Given this list of marker genes UBA2, DBI, CKAP2, RHPN2, AURKA, YWHAQ, BLTP3B, KPNA4, MCM5, PYCR1, CDK1, PANK1, SUCLG1, PKIB, OSGIN2, CTPS1, CDC45, SOAT1, CCNB2 (NCBI Gene Id 9133), TM4SF1, MAD2L1, MSH2, ASS1, BIRC5, TXNRD1, DEK, IL2RA, ARHGEF26, GMNN, DYNLT3, SLC11A2, RAF1, NEDD9, H3C10, EZH2, EID2, NETO2, CSTF3, NAA50 (NCBI Gene Id 80218), NXT2, GPA33, LINC00173, TSC22D2, CDK2 (NCBI Gene Id 1017), CDCA8 (cell division cycle associated 8), IDH2 (isocitrate dehydrogenase (NADP(+)) 2), TACC3, COX7B, WDHD1, SERP1, TWSG1 (NCBI Gene Id 57045), USP14, CENPF, TFRC, PLK1, MCM8, CENPQ, E2F1, DYNC2I2 (NCBI Gene Id 89891), SKA2, PRC1, TGFBRAP1, PDXP, FAM136A, IL17RB, RBBP7, BUB1, ACOT2, IMPA2, SCML1, H2BC5, AFDN, LIG1, H1-2, LINC01128, AK2, RACGAP1, HMGB2, NASP, ORC1, PRPS2, ZNF148, DLGAP5, BLVRB, RUBCN, SLC39A8, STBD1, PPA2, MNS1, PSMD11, SIRT2, NDUFA9, HLTF, MIS18A, MOBP, RBM38, AP1S2, GCA, RAB11FIP4, CLPTM1L, NUCB2, CRIPT, ING1, ANXA4, NCOA6, RAD1, PRDX4, KIFAP3, RBBP4, GUCY1A1, NCAPG2, CEP85, MDC1, ZWINT, GNPAT, KIF2C (kinesin family member 2C), CKS1B, PPAT (phosphoribosyl pyrophosphate amidotransferase), TK1, PRSS3, FIGNL1, TLK2, ALAS2, PAK1IP1, RAD18, HACD2, CENPN, PCNA, TYMS, PHF2, AKAP12, RBL1, TAF11, NEMP1, CPD, GLO1, APOBEC3B (NCBI Gene Id 9582), CDC25A (NCBI Gene Id 993), BTG3, TRMT6, TMPO, CHAF1A, UBE2C, KAT14, PLAGL1, DBF4, RNFT2, FAF1, TOP2A, NTRK2, MORC4, TMEM97, PLK4, SEC62, CSTF2, SEC23B, CCNB1, ACOX1, ADAM17, PXMP4, STMN1, KIF23, NEU1, RFC3, KIF14, VAMP7, EXO5, SPATA13, COPB2, TARS1, HMGN2, TNFAIP1, PARD6B (par-6 family cell polarity regulator beta), CDKN2C, RASSF2, RNASEH2A, RFC4, PPP1R14C, TEX30, KIF11, CMSS1, TEAD2, REEP6, BRIX1, NQO2, RRP1, SNX4, POLDIP2, RPN1, RCAN1, MELK, NCEH1, HMOX1, ATP6V1C1, AOC1, RPA3, ZYG11B, ZNF587, INSIG1, SMIM29, ARRB2, HENMT1, MRPS12, SNTA1, METTL2A, MORN2, RMI2, CEP55, CCSAP, LIG3, SAE1, E2F8, MLF1, TMED5 (NCBI Gene Id 50999), PLAAT3, GGH, BCL2L1, SLFN11 (schlafen family member 11, NCBI Gene Id 91607), TTC39A, FAM83D, ERBB2, GINS2, OSBP, CDC7, ITPR1, PIGC, SLFN13 (NCBI Gene Id 146857), MAD2L2, CENPE, SSX1, PGM3, RAD51C, TRAIP, KIFC1, SLC25A40, GAGE12F, MED8, ACSL4, KIF4A, TMEM106C, LNPK, CSRP3, RASL11B, GOLT1B, TBC1D23, GMCL1, REXO5, MCM4, ALAS1, H2AZ1, MAPRE1, BCAR3, MKRN2, AKR1B10 (aldo-keto reductase family 1 member B10), KPNA2, TFG, PSMC4, SHMT1, EXO1, MAGEA6, HSPD1, GNB3, PTTG1, C5orf22, EPHX1, TESK2, EBP, PEPD, TRIP13, UCK2, CDT1, OR4F16, FAM200B, ALDH9A1, ATG5, DAB2, DEPDC1, GPATCH11, MTHFD2, RAD54L, TOM1L1, CENPU, POC1A, CHAF1B, ST8SIA3, FABP3, POP4, MYBL2, DDAH1, RGS16, RRM2, WDR53, CDC6, ZNF286A, PPM1D, VRK1, OTULIN, PIK3AP1, RTN3, BRCA1 (NCBI Gene Id 672), GGCT, XPOT, ACSL1 (NCBI Gene Id 91249), TINCR, ANKRD27, URI1 (URI1 prefoldin like chaperone), NUPR1, PRDX1, CENPA, CXCL14, TCF19, PEBP1, SAC3D1, AKR7A2, NEK2, MCM6, SLC23A1, DAPK1, YARS1, ATAD2, ZNF232, CKS2, MRPL48, C12orf75, CCNE1, H2AZ2, ACADM, RAD51, here is a description of the gene set: Human Gene Set: LINDGREN_BLADDER_CANCER_CLUSTER_3_UP from publication Lindgren D, Liedberg F, Andersson A, Chebil G, Gudjonsson S, Borg A, Månsson W, Fioretos T, Höglund M (PMID 16532037) We used gene expression profiling, mutation analyses of FGFR3 and TP53, and LOH analyses of chromosome 9 and the TP53 region on chromosome arm 17p, to molecularly characterize 75 Ta and T1 bladder carcinomas. We identified four major cellular processes related to cell cycle, protein synthesis, immune response, and extra cellular components that contribute to the expressional heterogeneity of early-stage urothelial cell carcinoma (UCC). Activating FGFR3 mutations were found at the highest frequency in G1 tumors (80%), and showed a strong correlation with FGFR3 expression. In contrast, G3 tumors displayed mutations in less than 10% of the cases and a low level of FGFR3 expression. Even though LOH on chromosome 9 was not associated with any specific expression pattern, our data indicate that loss of chromosome 9 is associated with tumor development rather than initiation. The combined analyses suggest the existence of two types of UCC tumors, one which is characterized by FGFR3 mutation or expression, high expression of protein synthesis genes, and low expression of cell cycle genes. Furthermore, the presented data underscore FGFR3 receptor involvement in urothelial cell transformation as the presence of FGFR3 mutations has a major impact on the global gene expression profile of bladder carcinomas. studied in species Homo sapiens Genes whose expression profile is specific to Cluster III of urothelial cell carcinoma (UCC) tumors.